The following is a description of a gene set: species: Mus musculus An endodeoxyribonuclease complex that resolves the 4-way DNA intermediates of a Holliday junction into two separate duplex DNA molecules. Can be branch-migration associated. Mouse Gene Set: GOCC_HOLLIDAY_JUNCTION_RESOLVASE_COMPLEX, and this is the list of marker genes: Slx4 (NCBI Gene Id 52864), Eme2, Mus81, Rad51c, Eme1